Given this list of marker genes ATP5MK, NDUFA2, CENPK, ZNF239, CUTA (cutA divalent cation tolerance homolog), H3-4, RANBP1, POLR2K, STMN1, ATP5MG, CDK1, PSPH, DTL, CDC45, DNAJC8, MYC, CYB5B, AP2S1, APRT (adenine phosphoribosyltransferase), U2AF1, F2R, MRPS28, BLM, BRCA1 (NCBI Gene Id 672), CBX6, CBX5, AURKA, E2F8, NUCB2, CDCA8, RRM2, TTK, GCH1, PDXK, DHFR, MX1, SLC25A6, MRPL51, KRTCAP2, ALYREF, SURF2, DRC1, PRC1, NAA15, NDUFB6, HOXA7, ROMO1, MRPL41, USP3, MYBL2, PDCD5, ELOVL6, ATF5, PSMB3, RAD51, SLC31A1, MCOLN2, WDTC1, AHCY, ROM1, RWDD4, TPD52L1, SIRT3, TAMM41, CEP89, FLOT1, S100A10, POLR3K, CKS1B, MCM7, TIPIN, UNC119, EXO1, MCM10, MAD2L1, IL15, NUDT1, ATP5MC2, CMC2, TFDP1, KIF23, POLR2L, PGAM1, KIF11, CCNB2, PARM1, BIRC5, SELENOH, CCDC28B, IGFBP7, MRPS10, LUM, CDCA3, RBP1, UQCRQ, SEC13 (SEC13 homolog, nuclear pore and COPII coat complex component), CKAP2, ADA, C19orf53, NVL, CENPE, ANAPC13, CXXC5, LORICRIN, ORC6, HLA-DOA, HSDL2, KDM6A, MAP3K8, CDC6, SET, KIF4A, ASF1B, RFC5, GZMB, NDUFA5, CCR9, ATP5IF1, SUPT4H1, BAG6 (NCBI Gene Id 7917), CISD1, TOP2A, SLC25A53, NFE2, SSX2IP, RPS26, HEMGN, ID3, KDELR2, SLC25A4, KPNA6, YJU2, RAD51B, TBC1D24, DDC, SAP30, HK2, SYCE2, PLP2, DDX49, MRPL27, CHPT1, SNHG6, MCM2, UHRF1, MRPL54, SRI, SFXN1, PCLAF, CHEK1, FABP5, AURKB, WDR55 (NCBI Gene Id 54853), NXT1, ACTN2, CDC20, PSMB6, ATOH7, CTSW, NDUFAB1, COL4A1, UBL5, KIF22, FLT3, ANXA2, ORC1, ITGAE, RACGAP1, RGL1, CCNA2, KRTAP19-5, CD160, CDIP1, PLAC8, TMEM223, EVX1, DIAPH3, BMPR2, CDCA5, ANXA1, LPL, TXN, ADAM19, MTR, NEK2, SOD2, NCAPH, BRCA2, ANLN, CDT1, SGCD, CDC25C, E2F1, MRPL34, ECT2, CD8A, CD8B, BARX1, NUSAP1, here is a description of the gene set: studied in species Homo sapiens from publication Ji Y, Pos Z, Rao M, Klebanoff CA, Yu Z, Sukumar M, Reger RN, Palmer DC, Borman ZA, Muranski P, Wang E, Schrump DS, Marincola FM, Restifo NP, Gattinoni L (PMID 22057288) Mouse CD8+ T cells affected by ID3 (Inhibitor of DNA binding 3) display patterns of gene expression suggesting enhanced persistance and survival. In this study, we identified genes differentially expressed between ID32a transduced and mock transduced, and ID32a knockout and wild type mouse CD8+ T cells. Most prominent functions of differentially expressed genes include DNA replication-associated repair, maintenance of chromosome stability and mitotic cell divison machinery. Overall, these data suggest that ID3 acts in favor of maintained survival in CD8+ mouse T cells. Human Gene Set: GSE23568_CTRL_VS_ID3_TRANSDUCED_CD8_TCELL_DN Genes down-regulated in CD8 T cells: control versus over-expressing ID3.